Given this list of marker genes SLC6A9, SOD1, GCSH, BRAT1, PLAA, HIKESHI, TNIK, TRAK1, KLC2, GLRB, ARHGEF9, GRIA4, HEXB, ZMYM2, HEXA, CACNA1I, PURA, ASNS, GPHN, DENND5A, GM2A, GLRA1, GLB1, SLC6A5, DDC, FLRT1, FTH1, MTHFS, TEFM, MED11, PIGA, FKTN, TSPYL1, here is a description of the gene set: species: Homo sapiens An exaggerated startle reaction in response to a sudden unexpected visual or acoustic stimulus, or a quick movement near the face. Exaggerated startle response Human Gene Set: HP_EXAGGERATED_STARTLE_RESPONSE